The following is a description of a gene set: Human Gene Set: REACTOME_CHONDROITIN_SULFATE_BIOSYNTHESIS studied in species Homo sapiens Chondroitin sulfate biosynthesis, and this is the list of marker genes: CSGALNACT2, CHPF, CHST13, CHST3, CHST7, CHPF2, DCN, CHST12, CSPG5, CHST9, CSPG4, BGN, VCAN, NCAN, CHSY1, CHSY3, CHST11, BCAN, CHST15, CSGALNACT1